Given this list of marker genes HRAS, RAPGEF1, KRAS, PDGFRB, CRKL, PIK3R2, STAT1, BCAR1, NCK1, PLCG1, NRAS, CRK, PDGFB, STAT6, PDGFRA, RASA1, PIK3CB, PIK3CA, PTPN11, STAT5A, GRB2, PDGFA, SRC, STAT3, NCK2, SOS1, STAT5B, GRB7 (growth factor receptor bound protein 7), PIK3R1, here is a description of the gene set: studied in species Homo sapiens Reactome Pathway: Downstream signal transduction The role of autophosphorylation sites on PDGF receptors are to provide docking sites for downstream signal transduction molecules which contain SH2 domains. The SH2 domain is a conserved motif of around 100 amino acids that can bind a phosphorylated tyrosine residue. These downstream molecules are activated upon binding to, or phosphorylated by, the receptor kinases intrinsic to PDGF receptors.<br>Some of the dowstream molecules are themselves enzymes, such as phosphatidylinositol 3'-kinase (PI3K), phospholipase C (PLC-gamma), the Src family of tyrosine kinases, the tyrosine phosphatase SHP2, and a GTPase activating protein (GAP) for Ras. Others such as Grb2 are adaptor molecules which link the receptor with downstream catalytic molecules. part of: Signaling by PDGF